The following is a description of a gene set: Neighborhood of MYD88 species: Homo sapiens Neighborhood of MYD88 myeloid differentiation primary response gene (88) in the GNF2 expression compendium Human Gene Set: GNF2_MYD88, and this is the list of marker genes: LILRB1, ACTR2, LYN, SKAP2, FMNL1, DAZAP2, THEMIS2, RAB8A, ADA2, RHOA, SH3BGRL3, OSTF1, ARPC5 (actin related protein 2/3 complex subunit 5), TNFRSF1B, RNASET2, RIN3, USP3, ITGB2, SH2B3, RGS2, IQGAP1, STAT6, TYROBP, PSMB10, HLA-B, WAS, ARPC1B, HCLS1, PTPRE, CORO1A, LSP1, CYBA (NCBI Gene Id 1535), PYCARD, LILRA6 (leukocyte immunoglobulin like receptor A6), PAK2, TCIRG1, MAN2B1, MX2, SELPLG, CASP1, CYBB, MCL1, LST1, GMIP, ARPC3, PRKCD, CMTM6, DOCK2, ELF4, RPS6KA1, FKBP15, FCER1G, TMEM127, CNPY3, SELL, CYTH4, CAP1, CD53, MYD88, RAB5IF